The following is a description of a gene set: species: Homo sapiens Objective: We hypothesized that type 1 diabetes (T1D) is accompanied by changes in gene expression in peripheral blood mononuclear cells (PBMCs) due to dysregulation of adaptive and innate immunity, counterregulatory responses to immune dysregulation, insulin deficiency and hyperglycemia. Research Design and Methods: Microarray analysis was performed on PBMCs from 43 patients with newly diagnosed T1D, 12 patients with newly diagnosed type 2 diabetes (T2D) and 24 healthy controls. One and four month follow-up samples were obtained from 20 of the T1D patients. Results: Microarray analysis identified genes differing in expression between newlydiagnosed T1D patients and controls at a false discovery rate of 0.05. Changes in expression of interleukin-1β (IL1B), early growth response gene 3 (EGR3), and prostaglandin-endoperoxide synthase 2 (PTGS2) resolved within four months of insulin therapy and were also observed in T2D suggesting that they resulted from hyperglycemia. With use of a knowledge base, 81/genes could be placed within a network of interrelated genes with predicted functions including apoptosis and cell proliferation. IL1B and the MYC oncogene were the most highly-connected genes in the network. IL1B was highly overexpressed in both T1D and T2D, whereas MYC was dysregulated only in T1D. Conclusion: T1D and T2D likely share a final common pathway for beta cell dysfunction that includes secretion of interleukin-1β and prostaglandins by immune effector cells, exacerbating existing beta cell dysfunction, and causing further hyperglycemia. The results identify several targets for disease-modifying therapy of diabetes and potential biomarkers for monitoring treatment efficacy. from publication Kaizer EC, Glaser CL, Chaussabel D, Banchereau J, Pascual V, White PC (PMID 17595242) Human Gene Set: GSE9006_1MONTH_VS_4MONTH_POST_TYPE_1_DIABETES_DX_PBMC_DN Genes down-regulated in comparison of peripheral blood mononuclear cells (PBMC) from patients with type 1 diabetes at 1 month after the diagnosis versus those at 4 months later., and this is the list of marker genes: BGLAP, CELSR3, EIF4E, TUBA4B, UPB1, C4BPA, PPP4R3A, AK2, KCNJ10, EPHA1 (NCBI Gene Id 2041), FOXN3-AS2, TMED7, KRT23 (keratin 23), GUCY2F, TFCP2, NPBWR2, OSBPL10, GART, HAND1, RAB3A (NCBI Gene Id 96387), GHRH, MMP1, IL1R1, SRRD, DCLK1, USP27X, SLC7A2, ZNF157, ARNT, CYP2B6, DNAJB4, SPRR2B, SLC24A2, MGAT5, RCC1, SFPQ, NEUROG2, NTRK3, CRHR1, TGM3, RENBP, INHA, GKN1, HSP90B1, PCLO, COL5A3, PGBD5, GOLPH3L, DCTN1, RECK, HS3ST3B1, RHOA, POP1, EDN1, KLRC4, RHD, LY6G6D, NDUFA3, MBTPS2, LINC02249, IGKC, SLC66A3, TMOD1, ZNF507 (NCBI Gene Id 22847), CD58, ZNF586, LFNG, NRIP2, RAB30, SHOX, PRKAA2, FCMR, SP1, ZNF764, ZNF221, ZNF816, FGF22, SH3GL3, TRIM45, GPR132, OBSCN, CSN2, KRT17, CKLF, UBA52, AQP5, MBD5, HYAL2, COL2A1, PRSS50, TRPC3, NDUFA2, OR12D3, ZKSCAN8, STAM2, TPT1P8, PSMF1, SUMO3, PCSK2 (NCBI Gene Id 5126), FAP, CPLX2, H2BC15, POMP, MEF2A, OR7A17, PAX8, PRODHLP, CHRNA3, TSNAX, MDM4, ZNF550, MCTP2, FAM114A2, ITGB1BP2, MTMR6, PTMS, CA4, CPA4, ZBED2 (zinc finger BED-type containing 2), SLC17A4, FERMT2, COX7B, CFAP43, LMAN1L, CT55, GUCY2D, CLDN3, ETNK1, KCNJ5, GUCY1A2 (NCBI Gene Id 2977), NUMB, RABIF, LRRN2, GOLIM4, COX6A1, EXD2, RGS16, CLCN4, BET1 (NCBI Gene Id 10282), CACNA1D, P2RY4, GPRIN2, ADAMTSL2, PPP5C, NAV2, TJP3, LSM1, EPHA3, DENND2B, CNIH1, PLEKHA4, ASB4, B3GNT2 (NCBI Gene Id 55878), MBNL3, ABCC2, RHBDD3, ZNF230, S1PR1, KDM4A, DR1, KRT34, GRAPL-AS1, ATP6V0E1, ARFRP1, SIAH1, BAIAP2, TMPRSS2, CD72, MATN1, KLHDC8A, CDK20, TFF1, IGKV1D-13, DRC3, PTEN, AGXT, F10, TSG101, ENTPD7, SERPINF2, BHLHE41, FZR1, APOO, TPO, SLC2A2, GABRA2, CLDN17, RAMP1, NR1I3, LEPROTL1, CDH15, ERI3, TRMT13, JMJD4, HAPLN1, GSTO1, NEDD8 (NEDD8 ubiquitin like modifier)